Given this list of marker genes TULP3, MTHFD1, GLI3, HOXA1, MTHFD1L, FGF8, NDST1, MED12, here is a description of the gene set: species: Homo sapiens The process in which the anatomical structures of the neurocranium are generated and organized during the embryonic phase. The neurocranium is the portion of the vertebrate skull surrounding the brain. Human Gene Set: GOBP_EMBRYONIC_NEUROCRANIUM_MORPHOGENESIS